The following is a description of a gene set: studied in species Homo sapiens Murine Cytomegalovirus (MCMV) infection leads to early activation of various immune cells, including B and T lymphocytes, before the actual initiation of antigen-specific adaptive immunity. This activation is partly driven by innate cytokines, including type I interferon (IFN), which are induced early after infection. The objective of this study was to address the role of type I IFN in shaping early/innate B and T cell responses to a primary acute viral infection. In order to decipher the specific impact of IFN-I on cell subsets, we performed a genome-wide expression analysis on WT splenic B and CD8 T lymphocytes isolated from C57BL/6 mixed bone marrow chimera mice. This study complements series GSE39555, which focused on early responses of NK cells and of the two subsets of conventional dendritic cells. Human Gene Set: GSE45365_NK_CELL_VS_CD11B_DC_UP Genes up-regulated in NK cells versus ITGAM+ dendritic cells., and this is the list of marker genes: GLI1, ZNF619 (zinc finger protein 619), TEKTIP1, IZUMO4, CYP2C19, TTC36, ZNF606, UBXN2B, TAC3, SHLD1, C16orf95, PTH2, HEPACAM, VWA3A, FUZ, SLC35G1, ZBTB3, STX2, USE1, LRRC19, ZNF251, TMEM26, CCNI (NCBI Gene Id 10983), COL26A1, FAM168A, SPACA4, OXCT2, OXT (oxytocin/neurophysin I prepropeptide), HCG4, ABCC5, CTNNBIP1, TMEM163, FAM43B, NKX2-8, SIGLEC7, TMEM63C, AHSG (NCBI Gene Id 780898), NR1I2, COL25A1, ASGR2, CDH23, HDAC10, USP9Y, SRGAP3, TSGA13, XPNPEP2, CLEC2L, DPF3, CIMIP5, PRM3, VIL1, ACCS, VWCE, PPFIA2, PLSCR4, ZFP14, CCDC116, CHRNA3, IDO1, KRTAP11-1, SIRT6, SHISAL1, SENP7, UGT2A3, COL2A1, PRKCZ, ALK, DRD4, ATG7, BCL11A, MC3R, PRR12, ELAVL3, TRIM72, MIIP, MYCN (NCBI Gene Id 53360), HOXD13, MOV10L1, SAPCD1, ASCL2, SP5, M1AP, LZTS2, CD5 (CD5 molecule), COMMD9, GABRA2, FAM3A, LRP1B, DTNB, RBP3, RNF5, GDF11, DNAI3, ZNF691, ATOH8, RIMS3, KIF11, GOT1L1, MMP7, PCSK4, PNMA5, KCNE1, KRT8, CCDC172, NCAN, PAQR5, ZFP57, GPR143, KRT86, NMBR, CRACD, STEAP3, TMEM144, XK, L3MBTL2, ACVR2B, TRAIP, PROX1 (NCBI Gene Id 5629), PIMREG, ISL1, PIGL, GRIA1, RPUSD1, RIMS4, PHF19, ZNF414, GLT6D1, HELZ, ZNF212, PLEKHH2, LIM2, ARID3A, TRIM62, CDC14B, ZNF707, GDAP1L1, AMELX (amelogenin X-linked), GABRG3, APH1B, CCDC51, INTS14, GINS2, SOHLH1, MSH5, ASPHD2, CES5A, DERL3, KLHL26, RAD9B, MUC16, KRT31, VPREB1, RTN1, KCNK12, PDE11A, SLC22A12, DPPA5, MSX2, GLRA4, CTSW, NUDT16, MBD4, CYP2W1, CALCOCO2, TMEM190, SLC16A11 (solute carrier family 16 member 11), CTTNBP2, NEU2, EPN2, PKD1L2, CCNJL, ZSCAN12, HOXD12, SPMIP5, TUBE1, SYNGR1, TMEM121, TMPRSS6, GABRR1, BTBD2, CHCT1, CUL9, ZMYND15, B3GAT1 (NCBI Gene Id 964), SLC6A11, OLIG1, ROPN1L, PTPRR (protein tyrosine phosphatase receptor type R), TTLL8, MFSD13A, TLX1, PROX2, MAB21L3, POMT1, TMC8, METTL17, SOX11, LRR1, KRT73